The following is a description of a gene set: Binding to a growth factor receptor. Human Gene Set: GOMF_GROWTH_FACTOR_RECEPTOR_BINDING studied in species Homo sapiens, and this is the list of marker genes: PSEN1, CD300LF, IL1B, SDCBP, FGF9, FLRT3, TIMM50, AREG, GREM1, EFEMP1 (NCBI Gene Id 399564), IL23R, IL1F10 (interleukin 1 family member 10), DAB2IP, ADAM17, PDGFRB, FAM83B, FGF5, CNTF, SNX2, SOS1, VAV2 (NCBI Gene Id 7410), FGF8 (NCBI Gene Id 2253), EREG, EPGN, ERAP1, GLMN, FGF6, ARF4, ERBB4, SNX1, FLRT1, ITGA5, TLR9, FRS3, TGFA, AGR2, NPTN (neuroplastin), IL1R1, IL11, LYN (LYN proto-oncogene, Src family tyrosine kinase), IL5, IL12B, PLSCR1, IL7, IL37, IL36A, FGF2, GDNF, IL12RB1, CCDC88A, HIP1, EGF, CSF3, MYD88, PDGFC, IL6R, NRXN1, CSF2, SHC1, RNF126, FGF20, ATXN2, VEGFC, GATA3, PDGFA, TRIP6, PSPN, VEGFB, FGF4, KLB (klotho beta), ITGB3, PYCARD (NCBI Gene Id 29108), CBLC, PTPRJ, IL9, FGF10, IL10, ERN1, IL1A, VEGFA (vascular endothelial growth factor A), FGF7, ECM1, IRAK4, FGF19, TNK2, NRTN, PGF, PDGFB, NCSTN, ARTN, PDGFRA, IL36B, FGF22, FGF12, FGF17, CNOT9, FYN, IL3, TLR5, FER, BTC (betacellulin), NHERF1, GRAP, VEGFD, FGF3, SOCS5, IL2, FGF1, LINGO1, SLA, FRS2, ESM1, APP, PIBF1, IL36G, FGF14, FGF18, GRB2, KL, PDCL3, TSLP, CADM4, IL1RN, IL6, IL6ST (interleukin 6 cytokine family signal transducer), SNX4, FGF23, IL21, FGF16, FGF21, IL12A, CDH5, VAV3, JAK2, TOLLIP, RNF41, FLRT2, MS4A1, IL4, HBEGF, IL36RN, PDGFD